Given this list of marker genes CHN1, EXOC2, GDF6, NR2F1, FZD5, PLXNA1, POLR3A, HESX1, NFIX, FANCB, SRD5A3, ARSL, MAFB, SNAP29, DDHD2, TRIT1, HNRNPU, APC, SALL4, GDF3, here is a description of the gene set: studied in species Homo sapiens Optic disc hypoplasia Underdevelopment of the optic disc, that is of the optic nerve head, where ganglion cell axons exit the eye to form the optic nerve. Human Gene Set: HP_OPTIC_DISC_HYPOPLASIA